The following is a description of a gene set: from publication Busslinger GA, Weusten BLA, Bogte A, Begthel H, Brosens LAA, Clevers H (PMID 33691112) species: Homo sapiens Human Gene Set: BUSSLINGER_GASTRIC_PARIETAL_CELLS, and this is the list of marker genes: DECR1, UQCR10, NDUFA6, UQCRB, IGFBP5, ALDH1A1, EZR, SULT2A1, ATP5MC1, CPEB4, NDUFB3 (NCBI Gene Id 4709), DBT, COX4I1, ATP4A, MTURN, VDAC2, ECHS1, YBX1, BOLA3, PDHX, SOD1 (NCBI Gene Id 6647), NECAB3, CD59, NDUFB2, ME3, SGK1, GOT2, SLC25A4, CALM1, SDHB, RAB4A, ATP5PD, RAP1GAP, ACADVL, MDH2, COX6A1, SLC9A3-OT1, COX5B, IGFBP2, ISCU, ATP5MF, FILIP1L, GLOD4, HADHB, COX6C, ATP5PF, AQP4, ATP6V1H, ALAD, ATP5MC3, UQCRQ, SDHC, COX5A, TPM2, NDUFB10, ATP5ME, ACAT1, G0S2, CHIA, MICALL1, UQCRC2, ATP5F1A, FAM107B (NCBI Gene Id 83641), COX6B1, SIGLEC11, SMIM11, LDHB, ALDOB, DRD5, SUCLG2, SIK2, APLP1, CCKBR, CYFIP2, BCKDHB, REXO2, UQCRFS1, KCNJ16, SLC2A12, CYSTM1, NDUFB4, TMEM70, PRDM16-DT, KIAA1191, GRIA4, TBCA, GLUL, ECI2, ATP5F1C, PRDX5, GABARAPL1, CHCHD10, CPA2 (NCBI Gene Id 136262), NDUFS4, ETNPPL (NCBI Gene Id 64850), PRDX2, PRKAR1A (NCBI Gene Id 5573), NDUFB7, MDH1, COX7A2L, VDAC1, WBP2, PSCA, ATP4B, MPP7, HIGD1A, MGAT4B, TPD52L1, PRKACB, FGB, SERF2, ITIH5, UQCRC1, MPC2, AUH, NDUFB9, ATP5MK, MYO19, UBL3, OXCT1, PBXIP1, IDH2, LRIG1, PTGER3, CNTD1, EIF5A2, PSAP, HSPA9, PHLDA1, PAFAH2, PXMP2, CLIC6, ATP5F1B, ETFRF1, NDUFB8, NDUFS3, GPR155, ATP1B1, NDUFA8, NDUFAB1, PPP2R5A, LIFR, CS, AKR7L, ARRDC4, COX8A, KCNE2, CKB, MPC1, PDGFD, GMPR, SLC4A2, DCXR, FAM162A, FH, PINK1, SYNJ2BP, FGA, COX7B, TRIM50 (tripartite motif containing 50), LINC00671 (NCBI Gene Id 388387), COX17, FGG (NCBI Gene Id 2266), CYCS, NDUFA4, SLC25A3, PLEKHB2, ESRRG, AK3, NDUFV1, ATP5PB, PKM, COA3, DLD, GBGT1 (NCBI Gene Id 26301), PDHB, C1orf116, NFE2L2, SUCLG1, MRPL34, GPC3, FTH1, CYC1, CBLIF, MRPL41, NDUFA5, ATP5PO (ATP synthase peripheral stalk subunit OSCP), SLC16A7, VEGFB, STX12, DUSP19, TCN1, NDUFS1, MICOS10, ATP5F1D, TXNDC17, HOPX, CHP1, CKMT2, NDUFV2, TMEM171, AKR7A3, RAP1GAP2, RBPMS2, GHITM, DNER, MFSD4A, COX7A2, ODAM, AIFM1, GSTA1, UQCR11, FNDC5, PPIF, NCKAP1, KCNQ1, COX7C, NHERF1, FGD4, NDUFB5, CHCHD2, NDUFC1, NDUFA7, TMEM141, SLC25A5, WIPF3, NDUFA10, FTL, GAPDH, NDUFS8, DUSP4, PRDX3, DHRS7, PPP2R3A, AHCYL2, ATP5MG, TMBIM6, RAB11FIP2, NDUFS2, GPT2, HPCAL1, PDHA1, ATP5MJ, NNT, NDUFA1, GOT1, ACADM, GUCA2B, GPRC5C, CMTM4, NDUFA9, INSIG1, CHPT1, TM7SF2